The following is a description of a gene set: studied in species Homo sapiens The immediate defensive reaction (by vertebrate tissue) to infection or injury caused by chemical or physical agents. The process is characterized by local vasodilation, extravasation of plasma into intercellular spaces and accumulation of white blood cells and macrophages. Human Gene Set: GOBP_INFLAMMATORY_RESPONSE, and this is the list of marker genes: PLCG1, CCR5, FCHSD1, AGR2, PRCP, CD28 (CD28 molecule), MIR17, LEP, ZC3H12A, CXCL1, IL6, MARK4, LYN, S100A9, CCL7, MIR204, PBXIP1 (PBX homeobox interacting protein 1), APOD, MEFV, IRF5, GPR33, ADGRE5, FOXP1 (NCBI Gene Id 87246), CCL17, HRH4, FNDC4, AGT, PSMA6, IL17B, TNF, PPP2CA, DDT, CD6 (NCBI Gene Id 923), TACR1, ABHD17A, MAPK7, ADAM17, FOLR2, AP3B1, CD40, BPGM, WFDC1, IGHG1, AKNA, ADCY1, F2, CRHBP, JAM3, CCDC39, CAMP, MIR766, RASGRP1, POMT2, PROK2, USP50, CALHM2, C1QTNF12, TNC, HCK, ELP6, PSEN1, MMP25, HLA-E, PARP4, CXCL9, TNFAIP8L2, IER3, OSMR, MIR657, GBP5, IL17C, RABGEF1, FCGR1BP, CXCL11 (C-X-C motif chemokine ligand 11), IL10, GPR141 (NCBI Gene Id 353345), MIR15A, TNFRSF11A, GSDMB, MIR129-1 (NCBI Gene Id 406917), DAB2IP, LATS2, CCR7, CEBPB, ITCH, RIPK1, EDNRB, MAPKAPK2, MIF, NR1H4, CYBA, CASP4, PER1, CXCL5, PLA2G2A, TBK1, PPBP, HDAC4, AIF1, MIR142, FCGR2C, GPR17, SELP, TLR4, PLD4, IL25, IL1RAP, SCN11A, SMAD1, ADGRE2, TRADD, CD47, CUL3, LTB4R, ZDHHC5, IL20RB, SNCA, ACVR1, AFAP1L2, IL17RE, CAMK1D, CASP3 (caspase 3), DUOXA2, MIR19B1, CMKLR1, LYZ, SMAD3, TICAM1, TNFRSF1A, ADORA2A, RB1, CCL13, TSPAN2, MIR19A, FBXL2, GPR32, RARRES2 (NCBI Gene Id 5919), IL22RA2, CASP12, SCN9A, SAA1, IL5, TLR3, MAPK9, NMI, CLEC12A, ESR1, MIR30C2, NFKB1, IL17F (NCBI Gene Id 112744), CYP19A1, ASS1, ITGAM, CCL11, AOAH, CYBB, PLAA, MFHAS1, NR1D1, MTOR, CRH, C5, AXL, NLRP14 (NCBI Gene Id 338323), IL13, DAGLB, FABP4, NR1D2, SBNO1, FFAR2, CCL21, MIR338, IL18R1, FURIN, MAPK8, SHPK, TRAF3IP2, RORA, MAP3K8, TLR1, CDO1, PRDX2, CERS6, FFAR4, GPSM3, CD81, P2RX7, CCL15, CCL1, PLK2, FFAR3, WNT5A, AKT1, AOC3, CHST2, GHSR, KLRG1 (killer cell lectin like receptor G1), METRNL, SOCS5 (suppressor of cytokine signaling 5), NR5A2, CCL4L2, THEMIS2, NCF1, SELE, CAMK4, FEM1A, CCL16, PTGDR, POLB, ACE2, MIR488, MIR590, BMP2 (NCBI Gene Id 650), IL34, MIR206, MIR26A1 (NCBI Gene Id 407015), PSTPIP1, LGALS9, CD68, LCN10, SPATA2, HAVCR2, P2RX1, PLA2G3, HK1, NOD1 (NCBI Gene Id 10392), OGT, CEBPA, CHID1, YES1, KPRP, NR4A1 (nuclear receptor subfamily 4 group A member 1), AHR, SERPINF2, PROC, CASP6, CCR3, C1QTNF3, MIR141, PXK, CHST1, TRIM31, PRKCQ, IKBKG, SERPINE1, S100A12, RICTOR, MIR144, GPER1, MIR324, SPHK1, IL17A, AHSG, ABCF1, SYT11, TRIM21, MIR920, CTSC, EXTL3, NFE2L2, CHI3L1, GBP2, CCL23, TREM2, FOS, TLR7, FCGR1A, BMP6, NR3C1, TLR9, NLRP6, SIGLEC10, TFRC, APOL3, NAMPT, NDFIP1, SLC18A2, PSMB4, PLP1, LARGE1, TCIRG1, MMP8, HDAC5, MIR199A1, HBA2, SLAMF1, WDR83, ZFP36, ADAM8, ALOX15, MIR205, ALOX5, NR1H2, CCL20, RPS6KA4, STAT3, COL6A1 (NCBI Gene Id 1291), RAB44, CHST4 (NCBI Gene Id 10164), CCN4, TICAM2 (NCBI Gene Id 353376), PPARD, KRT1, CXCR4, DHX9, PLSCR1, ACKR1, IL10RA, MGST2, RPS19, PIK3CD, MIR3909, ELF3, ADA, ABHD12, SBNO2, TMSB4X (NCBI Gene Id 7114), VAMP7, CD36, PDE2A, SHARPIN, MIR361, SCUBE1, IRF3, PSG9, RPS6KA5, POMGNT1, HMOX1, MIR146A (NCBI Gene Id 406938), BCL6, SPINK7, MIR145, ADCY8, PIK3AP1, SAA2, NFATC4, CPTP, TNFRSF4, GSDME, LRFN5, ISL1, AGTR1, FAM76B, GZMA, DUOXA1, LGALS2, C2CD4A (C2 calcium dependent domain containing 4A), SNX4, CCN3, GSDMD, ZEB2, HMGB2, TMEM258, TAC1, VPS54, CCL14, EPHB2, ABCD1, HDAC9, BMPR1B, NEAT1, MYD88, UFL1, LAT, ABCD2, C3AR1, UACA (NCBI Gene Id 55075), FCGR3A, MIRLET7G, NOS2, APCS, PTGFR, SAA4 (serum amyloid A4, constitutive), MBL2, HSPG2, C2CD4B, SIRPA, ITGB6, BLNK, EIF2AK1, MMP26, TSLP, CD200R1L, IL18, KNG1, IL2, IL31RA, LY86, CCR4, ACP5, CD5L, NOTCH1, CCL28 (C-C motif chemokine ligand 28), CD96, STING1, HP, CX3CR1, NLRP9, NCR3, ALOX5AP, IL2RA, NLRC3 (NLR family CARD domain containing 3), FXR1, UMOD, TGFB1, SYK, GATA3, PTPN2, CD200, IL16, NAGLU, PLA2G2E, ADM, LATS1, SPN, GPS2, RHBDD3, AIM2, RIPK2, IL17D, APP, GSDMC, CCL26, APIP, CD180, ELF4, FOSL2, NLRP10 (NCBI Gene Id 338322), NINJ1, HGF, HSPA12A, CXCR6, FKRP, APPL2, TRPV4, NLRP3, IKBKB, GHRL, REL, CST7, NFATC3, F11R, TIRAP, TREX1, IL6ST, TLR8, FPR2, LY96, REG3A, MAPK14, LDLR, BIRC2, PYDC1, MIR98, KCNK6, IFI27, IL1A, CCR6, IL20, DEFB114, PRKD1, IL36B, PF4, LPL, LIAS, IL15, CYSLTR1, MIR6869, PRKCZ, CELA1, MIR125A, MIR128-1, CX3CL1 (C-X3-C motif chemokine ligand 1), SLC39A8, ATAT1, CCL22, MIR22, LGALS1 (NCBI Gene Id 3956), BAP1, MIR31, ZDHHC1 (NCBI Gene Id 748), CUEDC2, LILRB4, CCL3, CRP, TRIM11 (tripartite motif containing 11), SETD6, PRKCD, TUSC2, LRP1, TNIP1, MIR221, TMED2, MIR675, VAMP8, STK39, NOX4, SMPDL3B, SERPINA3, PTGES, SOCS3, CYP26B1, BDKRB2, IDO1, MAPK13, IRAK2, TRIL, STAP1, RHBDF2, SUCNR1, CYLD, NT5E, EZH2, CCL25, TXNIP, ACOD1, SIRT2, GZMB, GKN2, ECM1 (extracellular matrix protein 1), NRROS, HYAL2, PLA2G4C, FUT4, FOXP3, ADORA3 (adenosine A3 receptor), ABCC1, APOL2, CARD8, NAIP, GGT5, LACC1, IL1B, FPR3, USP18, HBB, STAT5B, ZDHHC12, MSMP, ANO6, MIR195, NLRP8, SERPINA1, F2R, SRC, EIF2AK2, NLRP7, IL36RN, FCGR3B, CD14, RELB, HNRNPA0, TNFSF4, PLD3, RTN4, ENPP3, PBK, IL12B, HLA-DRB1, ABHD8, MIR15B, ODAM, RELA, TBXA2R, STARD7, CSNK1A1, AZU1, ADORA2B, SCNN1B, CD2AP, FPR1, NOX1, XCL1, MIR130B, CELF1, LY75, ARMH4, TLR10, PYDC5, NPY5R, PTPN6, FCER1A, TRPV1, HSPA8, TRIM55, NLRP5, ITGB1, MEP1B, XIAP, CCL18, BIRC3, TNFAIP3, STAB1, NFE2L1, PTGER1, DAGLA, GBP1, NR1H3, IFNGR2 (interferon gamma receptor 2), IRGM, ACER3, TOLLIP, GGT1, CSF1, MIR181A2, APPL1, MIR136, KCNK13, CSRP3, APOA1, GSDMA, NEK7, F2RL1, CCR1, GBA1, CXCR2, WNK4, CXCL2, MMP3, MAP2K3, CXCL3, VPS13A, PLCG2, PARK7, MARCHF5, PPARA, TIMP1, PRKCA, C4B, KIT, IL27, DNASE1, NLRP12, CASP8, SCGB1A1, TSPAN18, CAMK2N1, PTGIR, BRD4, ZP3, C5AR1, FOXF1, CXCL6 (NCBI Gene Id 6372), F3 (coagulation factor III), ITIH4, HYAL3, F8, CASP5, IL5RA, MAS1, TNFSF18, ADIPOQ, CXCR3, STMP1, PGLYRP2, TAFA3, RAC1, MIR4286, PLA2G2D, PJA2, ZNF580, FCER1G, MKRN2, IL17RB, NLRP11, PTGER2, MAP3K20, IL23A (interleukin 23 subunit alpha), ZDHHC9, ARNT, NDP, PGLYRP1, FANCA, NLRX1, KCNJ8, PTGER4, MMP9, XCR1, FN1, HIF1A, SLAMF8, TNFSF11, IL17RA, SELENOS (NCBI Gene Id 55829), CARD9, CD40LG, MIR187, BCR, MIR93, GRN, CHUK, MIR138-1, LRRC19, GPR68, PIK3CG, CXCL13, HYAL1, ADAMTS12, SMO, IL33, CD163, CCL5, TAB2, ADORA1, NFKBIA, CNTF, NLRP2, SIGIRR, TLR2, NFKBIB, DROSHA, LETMD1, CHIA (NCBI Gene Id 27159), PTPRC, FANCD2, IFNGR1, IL21, MIR21, FYN, SNX6 (NCBI Gene Id 58533, sorting nexin 6), ITGB2, MIR223, IGHE, AGTR2, MCPH1, CASP1, IL23R, DNASE1L3, SLC11A1, PTAFR, IL4, LXN, AGER, C3 (NCBI Gene Id 12266), TTBK1, MIR16-1, MIR222, FADS2, DDX3X, GPR32P1, TRIM65, TYROBP (NCBI Gene Id 7305), MIR140, LTA, IL17RC, CCL19, NKIRAS2, HMGB1, ACKR2, NPFF, B4GALT1, XCL2, RBPJ, KLF4, C1QA, C5AR2, IL1F10, HRH1, OSM, SCYL1, S100A8, MIR92A1, ADCY7, LRRK2, PTGIS, IL36G, LIPA (lipase A, lysosomal acid type), MACIR, APOE, IFNG, GBP3, SNAP23, CCL24, MIR302E, NLRP1, EXT1, MIR149, GGT3P, REG3G, MIR203A, NLRP2B, CCL4, TP73, CREB3L3, IL9, BRCC3, SCYL3, MIR126 (NCBI Gene Id 406913), PTN, TNFAIP6, IL1R1, S1PR3, PYCARD, SETD4, MIR181B1, FUT7, PLA2G10, MIR105-1, VAMP3, NFAM1, OLR1, KPNA6, MIR20A, IL6R, CLU, LAMP2, CLEC7A, BST1, CXCL17, C4A, IL37, VAMP2, BTK, FCGR2A, ORM2, NDST1, GSTP1, PRDX5, AIMP1, IL1RL1, ORM1, KRT16, PYDC2 (NCBI Gene Id 285305), CTNNBIP1, OTULIN, TAC4, PLGRKT, NFX1, CCL8, TRIM45, IL36A, PLA2G4B, FOSL1, TLR6, PPARG, MGLL, GPR4, CCR2, MAVS, NFKBID, FCGR2B, GNAT2 (G protein subunit alpha transducin 2), IGF1, ZBP1, IFNA2, LPCAT3, CMA1, NOD2, NOTCH2, DUSP10, KDM4D, IL1RN, LILRA5, IL18RAP, CARD18, CDH5, CCL3L3, MRGPRX1, KARS1, TMIGD3, SOD1, KDM6B, AREL1, HTR2A, IFI16, LOXL3, MDK, FAM114A1, SIGLEC1, NAPEPLD, NFKBIZ, NKG7, IL10RB, IL1R2, CCL2, BCL6B, VNN1, ETS1, HBA1, GIT1, CXCL10, MIR181C, INS (NCBI Gene Id 3630), CD200R1 (NCBI Gene Id 131450), ELANE, CNR2, TNIP3, DPP9, GGT2P, MIR378A, MAPT, CSF1R, NLRP13 (NLR family pyrin domain containing 13), DHX33, TLR5, CCRL2, PNMA1, MIR135A1, EPHA2, NLRC4, JAK2, FGR, PPP1R13L, NPY, UNC13D, FAM210B, CXCL8, BDKRB1, PSMA1, IL22, FASN, THBS1, GNAS, F12, ATRN, VPS35, CCL27, CLOCK, DPEP1, ITGAL, SEMA7A, KLKB1, PTPN22, ASH1L (ASH1 like histone lysine methyltransferase), CHRNA7, GPX1, LBP, LCN2, VCAM1, IFI35, DSG2, GPRC5B (G protein-coupled receptor class C group 5 member B), JUN, NLRP4, MIR197, TEK, TNFRSF1B, IL4R, PTGS2, PTGER3, TYRO3 (TYRO3 protein tyrosine kinase), MAP3K7, CD44, PTX3, ANXA1, EPG5, NUPR1, STAT5A, PLA2G7, MVK, TNIP2, FAM3C, GPR31, H2BC1, SCG2, EPO, PDCD4, PF4V1, IL1RL2, IL22RA1, TRIM14